Given this list of marker genes IFI16, ENAH (ENAH actin regulator), C3AR1, SYNGR1, KRT18, GJB3, CP, SEPTIN11, PSTPIP1, TIMP3 (NCBI Gene Id 7078), RASL11B, NGF, PARM1, CLEC4D, SLC22A23, TPD52L1, SLFN12, PLIN2, SQSTM1, EGFR, PTPRC (NCBI Gene Id 5788), CD53, CCN4, STAB1, HPGD, FERMT3 (NCBI Gene Id 83706), SLCO3A1, C1QA, IGFBP2, RHOB, IGFBP3, ZDHHC14, PLA2G7, PLAC8 (NCBI Gene Id 95621), KDM5B, ARL5A, NINJ1, PLD3, ATP6V0B, ACKR4, RPS6KA2, RABAC1, RB1, MLLT11, LCP2, PRDX2, COLGALT1, C1QB, DCN, MCCC1, IRF5, SHROOM3, UPK3B, TPH1, RNF149, PLSCR1, MEST, CA3, CRCT1, MS4A6A, RNF19B, GNG11, MSRB1, IFI30, HMOX1, CD300C, ACTG2, UBE2A, IL6, CFP, NDRG4 (NDRG family member 4), DCTN6, FBXO9, MIEN1, FABP7, MMP13, HTRA1, MSR1, EDN1, RBP1, SLC1A6, UCHL1, UBFD1, TYROBP, RENBP, VAV1, CSF1R, TRPV2, LMO2, TFPI (tissue factor pathway inhibitor), APOE, ADAM8, IVL, SKAP2, TGFB2, PON2, CCL2, GABRB1, TEC, SRGN, ACTA1, C1QC, LGALS9, GABARAPL1, CD14, MMP12, PRRC1, NPR3, SARAF, CADM1, CD59, H2BC4, CFH, H2BC1, HM13, CCL15, SPI1, NUPR1, CTSS, CCL3, TCEAL9, here is a description of the gene set: from publication Markey MP, Bergseid J, Bosco EE, Stengel K, Xu H, Mayhew CN, Schwemberger SJ, Braden WA, Jiang Y, Babcock GF, Jegga AG, Aronow BJ, Reed MF, Wang JY, Knudsen ES (PMID 17452985) Functional inactivation of the retinoblastoma tumor suppressor gene product (RB) is a common event in human cancers. Classically, RB functions to constrain cellular proliferation, and loss of RB is proposed to facilitate the hyperplastic proliferation associated with tumorigenesis. To understand the repertoire of regulatory processes governed by RB, two models of RB loss were utilized to perform microarray analysis. In murine embryonic fibroblasts harboring germline loss of RB, there was a striking deregulation of gene expression, wherein distinct biological pathways were altered. Specifically, genes involved in cell cycle control and classically associated with E2F-dependent gene regulation were upregulated via RB loss. In contrast, a program of gene expression associated with immune function and response to pathogens was significantly downregulated with the loss of RB. To determine the specific influence of RB loss during a defined period and without the possibility of developmental compensation as occurs in embryonic fibroblasts, a second system was employed wherein Rb was acutely knocked out in adult fibroblasts. This model confirmed the distinct regulation of cell cycle and immune modulatory genes through RB loss. Analyses of cis-elements supported the hypothesis that the majority of those genes upregulated with RB loss are regulated via the E2F family of transcription factors. In contrast, those genes whose expression was reduced with the loss of RB harbored different promoter elements. Consistent with these analyses, we found that disruption of E2F-binding function of RB was associated with the upregulation of gene expression. In contrast, cells harboring an RB mutant protein (RB-750F) that retains E2F-binding activity, but is specifically deficient in the association with LXCXE-containing proteins, failed to upregulate these same target genes. However, downregulation of genes involved in immune function was readily observed with disruption of the LXCXE-binding function of RB. Thus, these studies demonstrate that RB plays a significant role in both the positive and negative regulations of transcriptional programs and indicate that loss of RB has distinct biological effects related to both cell cycle control and immune function. species: Mus musculus Genes down-regulated in MEF cells (embryonic fibroblasts) isolated from RB1 knockout mice: chronic loss of function (LOF) of RB1. Human Gene Set: MARKEY_RB1_CHRONIC_LOF_DN